Given this list of marker genes ACTC1, FLNC, MYPN, MYL2, ABCC6, RPL3L, TLL1, MYH6, FLNA, TNNI3, NOTCH1, TBX5, GATA4, MYBPC3, NKX2-5, PPP1R13L, MPDZ, CITED2, GATA6, AGR2, TNNT2, TBX20, KIF20A, MCM10, BANF1, here is a description of the gene set: species: Homo sapiens Right atrial enlargement Increase in size of the right atrium. Human Gene Set: HP_RIGHT_ATRIAL_ENLARGEMENT